The following is a description of a gene set: Enables the transfer of dehydroascorbate, 5-(1,2-dihydroxyethyl)furan-2,3,4(5H)-trione, from one side of a membrane to the other. Mouse Gene Set: GOMF_DEHYDROASCORBIC_ACID_TRANSMEMBRANE_TRANSPORTER_ACTIVITY studied in species Mus musculus, and this is the list of marker genes: Slc2a8, Slc2a2, Slc2a1, Slc2a10, Slc2a3, Slc23a1